The following is a description of a gene set: species: Homo sapiens Any process that activates or increases the frequency, rate, or extent of B cell mediated immunity. Human Gene Set: GOBP_POSITIVE_REGULATION_OF_B_CELL_MEDIATED_IMMUNITY, and this is the list of marker genes: CD226, IL4, EXOSC3 (exosome component 3), CLCF1, PMS2, CD40, MLH1, KMT5C, NECTIN2, TP53BP1, KMT5B, CD28, XCL1, STAT6, TNFSF13, TGFB1, HMCES, FCER1G, PAXIP1, TREM2, SHLD1, RIF1, MAD2L2, ATAD5, PTPRC, SHLD2, MSH2, TNFSF4, LTA, EXOSC6, NSD2, TBX21, C3, BTK, FCGR1A, IL2, TFRC, C17orf99, FCER2, SHLD3, TNF, HLA-E, HPX